Given this list of marker genes SLC29A2, SLC28A1, SLC28A2, SLC28A3, SLC29A3, SLC29A1, here is a description of the gene set: The directed movement of uridine, uracil riboside, across a lipid bilayer, by means of some agent such as a transporter or pore. species: Homo sapiens Human Gene Set: GOBP_URIDINE_TRANSMEMBRANE_TRANSPORT